Given this list of marker genes NRAS, SERPINB2, BNIP3L, UBE2V2, CDK4, NFKB1, DNAJC3, MKI67 (marker of proliferation Ki-67), IL1B, E2F3, EREG, BCL2L1 (NCBI Gene Id 598), CLEC2B, PCNA, TNFSF10, CDC20, BNIP3, FAS, STK17B, G0S2 (NCBI Gene Id 50486), DUSP6, GSPT1, FCER2, BCL2A1, RAN, CFLAR, CDK6, CCND2, MBL2, BIRC5, CD2, CDC45, IL1A, NEDD9, BIRC2 (baculoviral IAP repeat containing 2), CD69, LGALS3, PLK1, IER3, BIK, MX1, BCAR3, IFITM1, E2F1, MYBL2, CCNB1, BIRC3, here is a description of the gene set: Viral anti-apoptotic evasion mechanisms. species: Homo sapiens Human Gene Set: MODULE_312